Given this list of marker genes POU3F2, XYLB, SPC24, USP40, PARVB, GSK3A, CUTA, TBCA, GYS1 (NCBI Gene Id 2997), GNG2, GLRX2, RIOX1, BIRC5, PAFAH2, USP39, ANO6, MCL1, ACLY, CTSE, NDUFA13, TTLL12, FN3KRP, MRPS26, RLN1 (NCBI Gene Id 6013), SPATA3, TTLL10, ACTR3B, ZIM3, CNIH2, QDPR, AP2A1, TNK2, AGPAT3 (NCBI Gene Id 83745), SH3GL2, UROC1, DBNDD2 (dysbindin domain containing 2), KCNK13, VCF1, ALDH2, TMX2, SETD4, ENGASE, CREB3L1, HOXB7, NACC2, ATP6V1G2, SQOR, NCDN, TTLL3, DNAJB5, MAP2K7, ABCD2, TXN2, TRAPPC2L, NFIA, PGP, HS3ST2, STARD9, COQ4 (NCBI Gene Id 51117), ST8SIA2, AFP, SHROOM4, BMP6, ARMC7, KCNJ3, GSS, TRIP4 (NCBI Gene Id 9325), BCDIN3D, GAS2, TTC13, GLUL, EPOR, NAA16, MCRIP2 (NCBI Gene Id 84331), ANK1, PELP1, GGACT, DNAJC30, C1orf216, RAB38, ZNF703, FEV, SOAT1, SEMA6C, API5, SLC39A13, TMEM98, SHH, CYP7A1, DSEL, PCDH1, RAB42, CELF3, ARRB2, CCT4, NSL1, TSEN2, ARSI, TPPP, NDUFB11, AGBL5, MALAT1, CYTH4, AGAP1, COX7A2L, HOMER2, PILRB, RNASEK, NDUFB5, TAOK2, RANBP3L, SNAP47, SF3B2, METAP2, EPN1, FAM174C, TOR1B, DUSP23, LRRC8D, YTHDF1, DBI, POLR1C, ENDOD1, MRPS25, HPS4 (NCBI Gene Id 89781), RPSA, MXD3, FBF1, RNASEH2C, CGRRF1, CA7, MOCS3, MAFB, KLF1, RAD51C, PIN4, CNTD1, SLC16A13, TMEM205, PPP1R36, MSL2, ADRB1, B3GNT2, NCAPH2, IGFBP5, OCRL, EDNRB, GAB1, LRRN4CL, GULP1, SPHK2, MYOM1, CNP, TIMM44, ITGB5, SUSD1, SNX8, CACNG7 (NCBI Gene Id 59284), NDUFB8, RBM10, PSMA8, INKA2, FGFR1, BMS1, SLC39A12, MINK1, RIPOR1, MARVELD2, AIF1, SRPK3, NOXRED1, KCNN4, OXLD1, LARP7, MRPL17, ROMO1, NOS1, HSD17B11, HIP1R, PRKCA, ACTL6A, FMO2, PRR15, COX10, UBAC1, CC2D1B, PER3, KAT2A, PLCXD3, PITPNC1 (phosphatidylinositol transfer protein cytoplasmic 1), CDC25A, GAPDH, HAUS4, TXLNB, HMOX1, ADGB, CCSAP, PFKM, TMEM161A, here is a description of the gene set: from publication Covens K, Verbinnen B, Geukens N, Meyts I, Schuit F, Van Lommel L, Jacquemin M, Bossuyt X (PMID 23613519) Human Gene Set: GSE42724_B1_BCELL_VS_PLASMABLAST_UP Genes up-regulated in B lymphocytes: B1 versus plasmablasts. The recent discovery of the human B1 cells, identified by the expression of CD20, CD27 and CD43 in absence of expression of CD70 and CD69 has been subject of debate. Some studies have raised the possibility that these cells are B cells differentiating towards the plasmablast and plasma cell stage rather than being the human counterpart of murine B1 cells. No further in depth studies have been performed. Therefore, a functional comparison was made between, the proposed B1 cells and plasmablasts. We observed that for several functional characteristics (distribution of isotypes of spontaneously producted antibodies, production of antigen-specific antibodies after vaccination with both T-cell dependent as well as T-cell independent antigen, the proposed B1 cells behaved similar to plasmablasts. In addition, we were able to differentiate the proposed B1 cells in vitro, indicating that they are not from a distinct lineage as the murine B1 cells. Gene expression analysis revealed that these cells cluster between memory B cells and plasmablasts, contradicting them being the genuine human counterpart of murine B1 cells, rather revealing a preplasmablast phenotype. species: Homo sapiens